Given this list of marker genes WNT5A, IL10, P2RX7, PERP, TGFB2, ZC3H8, IDO1, TP53, BAX, BBC3, LGALS16, CD274, ADAM8, LGALS9, CCL5, MYC, FNIP1, PDCD1, BCL2L11, PRELID1, here is a description of the gene set: species: Homo sapiens Human Gene Set: GOBP_POSITIVE_REGULATION_OF_LYMPHOCYTE_APOPTOTIC_PROCESS Any process that activates or increases the frequency, rate or extent of lymphocyte death by apoptotic process.